The following is a description of a gene set: studied in species Homo sapiens part of: Defects in biotin (Btn) metabolism Reactome Pathway: Defective HLCS causes multiple carboxylase deficiency Defects in HLCS causes holocarboxylase synthetase deficiency (HLCS deficiency aka early onset multiple carboxylase deficiency; MIM:253270). HLCS deficiency is an autosomal recessive disorder whereby deficient HLCS activity results in reduced activity of all five biotin-dependent carboxylases. Symptoms include metabolic acidosis, organic aciduria, lethargy, hypotonia, convulsions and dermatitis. Patients can present symptoms shortly after birth to up to early childhood and will be prescribed oral biotin supplements, typically 10-20 mg daily. Two classes of HLCS deficiency have been reported depending on whether patients respond to biotin therapy. Most patients respond favourably to treatment and show complete reversal of biochemical and clinical symptoms. Here mutations in the HLCS active site cause a reduced affinity for biotin that can be overcome by pharmacological doses of the vitamin. Patients who display incomplete responsiveness to biotin therapy have a poor long-term prognosis. Here mutations that reside outside of the enzyme's active site have no effect on biotin binding but do compromise the protein-protein interaction between the HLCS and its substrates, resulting in reduced biotinylation of all five carboxylases thus reducing their enzymatic activity., and this is the list of marker genes: PCCB, HLCS, PCCA, MCCC2 (NCBI Gene Id 64087), ACACA, PC, MCCC1